Given this list of marker genes Cfl1, Sharpin, Cd14, Aplp1, Grb2, Itm2a, Ddt, Psmb4 (proteasome (prosome, macropain) subunit, beta type 4), Cx3cr1, Map2k2, Pltp, Slc44a1, Rnaset2b, Sys1, Mgst1, Bbs9, Tle5, Tmed9, Dnmt3a, Klf2, Tmed4, Cst3, Jund, Sh3kbp1, Selenok, Ubb-ps, Hexb, Angel2, Ece1, Tmsb10, Tssc4, Tspan2, Kdm6b, Plvap, Cebpd, Cdkn1c, Gtf2b, Tlnrd1, H2-D1, Bin1 (bridging integrator 1), Lyz2, Sf3b4, Npdc1, Bri3, Osgep, Coro2b, Ssr3, Ltbp4, Tcf15, Gnptg, Nab2, Lgmn, Atp6v0c, Ccn1, Arpc1b, Egfl7, Tmem160, Ncbp2as2, Rnasek, Furin, Igfbp7, Hdac7 (histone deacetylase 7), Cnp (2',3'-cyclic nucleotide 3' phosphodiesterase), Depp1, Ptma, Ptprm, Crip2, Micu1, Eif4e2, Plekha1, Npr1, Lhfpl6, Gstm1, Ccdc85b, Ier2, Nudt16l1, H2ax, Cd9, Brd3, Ube2m, Glul, Swi5, Hsd3b7, Kmt2e, Tmem59 (transmembrane protein 59), Usp22, Rpl3, Nudt3 (nudix hydrolase 3), Prr13, Reep5, Tmem204, Thbd, Txn2, H2-K1, Rab5c, Cfap20, Tnfaip6, Tnfsf12, Apoa1, Rps5, Clic4, Rabac1, Tmed3, Acta2, Ifngr1, Ncor1, Pkm, Dhx38, Plscr2, Ncs1, Ppib, Sephs2, Mt2, Scamp2, Pfdn2, Ddx39a, Mospd3, Cryab, Eif1ax, Inka1, Ptms, Cldn5, Jpt1, Drap1, Ifitm2, Plek, Larp4b, Lims1, Park7 (NCBI Gene Id 57320), Vim, Rpl13a, Clu (clusterin), Csnk1e, Mir24-2, Lpcat2, Flii, Ctsb, Oaz1, Rhob, Csf1r, Gpx4, Lgalsl, Acer2, Sdc4, Prex1, Rbm39, Etfa, Cytl1, Atat1 (NCBI Gene Id 73242), Apoe, Abi3, Tomm6, Cltb, Tamalin, Zfp36, Smim14, Arhgdia, Rassf1, Gstp1, Olfml3, Scp2, Arpc3, Wbp2, H2-Aa, Dbnl, Hspa4, Myl12a, Selenow, Smad7 (NCBI Gene Id 17131), Mgp, Hspa1a, Cnpy2, Tesk1, Camk1, Dctn1, Srsf5, Sri, Nfkbil1 (NCBI Gene Id 18038), Arhgef2, Ndufa8, Ramp2, Ogn, Ifi27 (interferon, alpha-inducible protein 27), Serpinb1a, Zbtb7a, Snrpc, Calm2, Tmem11, Atraid, Rap1a, Atp9a, Laptm5, Lrrc8a, Trf, Ccn2, G3bp2, Rhoc, Serpinh1, Selenom, Ubald1, Cd63, Smco4, Pfn1, Gnb1, Lmo4, Spr, Anapc11, Ppil2, Cdc37, here is a description of the gene set: species: Mus musculus from publication Tabula Muris Consortium (PMID 32669714) Mouse Gene Set: TABULA_MURIS_SENIS_BROWN_ADIPOSE_TISSUE_ENDOTHELIAL_CELL_AGEING